The following is a description of a gene set: Any process that modulates the frequency, rate or extent of transcription elongation, the extension of an RNA molecule after transcription initiation and promoter clearance by the addition of ribonucleotides catalyzed by a DNA-dependent RNA polymerase. species: Homo sapiens Human Gene Set: GOBP_REGULATION_OF_DNA_TEMPLATED_TRANSCRIPTION_ELONGATION, and this is the list of marker genes: MED15, ELOA2 (NCBI Gene Id 51224), INTS9, INTS4, SCAF8, MED29, MAP2K1, MED25, MED4, INTS2, TCEA2, LEO1, BTBD18, CCNT1 (NCBI Gene Id 904), INTS13, EAF1, AXIN1, MED28, CDK9, NCBP1, SUPT16H, INTS5, MED20, ZMYND8, TCERG1, RN7SK, CDK12, MED16, VHL, MED10, SETD5 (NCBI Gene Id 55209), INTS8, MED30, ZNF326 (zinc finger protein 326), LARP7, INTS3, KAT7, PPP1R10, MED23, SIRT6, RNF168, INTS6, INTS1, CDK13, PWWP2B, INTS12, LDB1, ZMYND11 (NCBI Gene Id 10771), HEXIM1, GTF2F1, RNF8 (ring finger protein 8), SUPT5H, MED14, CDC73, MED6, SHH, PPP1CA, HMGN1, INTS7, NELFB, PWWP2A, MED27, MED22, ELL3, MED19, CCNK, CCAR2, WDR43, ELL (elongation factor for RNA polymerase II), MED8, WDR82, CTNNB1, NELFA, MED26, ZC3H4, EZH2, PARP1 (poly(ADP-ribose) polymerase 1), MED1, MED24, MED9, ERCC6, EAPP (E2F associated phosphoprotein), INTS10, CCNT2, NELFCD (NCBI Gene Id 51497), HNRNPU, BRD4, MED17, NCBP2, MED7, TOX4, INTS14, MED21, MED31, MED11, RECQL5, SUPT4H1, ELL2, INTS11, EAF2, MED18, NELFE, TSFM